Given this list of marker genes Erc1, Rims2, Pclo, Gucy1b1, Rims3, Ctnnb1, Iqsec2, Rims1, Ctbp1, Bsn, Stxbp1, Rimbp2, Ctnnd1, Ctbp2, Erc2, Nr3c2, Unc13a, Ppfia3, Osbpl2, Ctnna2, here is a description of the gene set: studied in species Mus musculus Mouse Gene Set: GOCC_PRESYNAPTIC_ACTIVE_ZONE_CYTOPLASMIC_COMPONENT A specialized region below the presynaptic membrane, characterized by electron-dense material, a specialized cytoskeletal matrix and accumulated (associated) synaptic vesicles.